The following is a description of a gene set: species: Homo sapiens Human Gene Set: MIR3187_5P from publication Chen Y, Wang X (PMID 31504780) Genes predicted to be targets of miRBase v22 microRNA hsa-miR-3187-5p in miRDB v6.0 with MirTarget v4 prediction scores > 80 (high confidence targets)., and this is the list of marker genes: CLSPN, TRMT13, YAP1, NECTIN1, PTGES3L, PRELP, RARB, PHF21A (NCBI Gene Id 51317), TRABD2B, SIDT1, RYBP, SEC14L1, HIVEP3, AHI1, ZNF322, NUFIP2, SRR, PPP2R2B, CRTC1 (CREB regulated transcription coactivator 1), C1orf210, KCNB1, DAB2IP, LRRC41, HOXA13, PRR14L, TANGO2, GABRA1, FGF14, ZBTB8B, RD3, SC5D, FOXP4, AKAP13, FMO5, CCNT1, GPI, SSH2, PTEN, NLRP14 (NCBI Gene Id 338323), RAB11FIP3, YTHDF1, RPL28, GAB2, SMAD6, GTPBP10, WNT4, PSD3, RC3H1, PLOD1, RMI1, ORAI2, APBB2, PRND, KDM2B, SEC63, ZNHIT6, SIKE1, ATP8A1, TCTN3, BTRC, FAM120C, GDNF, AP4S1, CKAP4, KCNK2, SPRTN, NFAM1, LRRTM3, CMTR2, GIPC3, SMPD1, APPBP2, ABCB8, NUDT19, CHL1, NOS1, CMKLR1, RBMS2, NDOR1, PLEKHM1, NF2, GRK6, CEACAM7, ACP6, COL4A5, IFT122, IPO9, CXXC4 (NCBI Gene Id 80319), ARNT2, TMEM41B (transmembrane protein 41B), ARF6, SRFBP1, TPI1, LRRC31 (NCBI Gene Id 79782), CCP110, FMOD, ZNF609, TFAP2A, TMEM127, LARP1, CREB5, PPP3CB, ARRDC3, FUS, DCTN5, SLC17A5, SLC25A12, FBXO33, GPR62, JRK, SAR1A (NCBI Gene Id 56909), MARCKSL1, DDX11, NRP1